Given this list of marker genes Slc6a1, Slc38a1, Eppin, Itga8, Rtn2, Pdpn, Treml4, Clec4e, Trpv1, Skint2, Adam6b, Tpo, Tnfrsf4, H2-M11, Hmgb1, Atp5f1a, Cd209d, Adgrf5, Abcg2, Hrg (NCBI Gene Id 94175), Btn2a2, Ager, Skint5 (NCBI Gene Id 670512), Chrnb2, Cd200r2, Cxcr2, Stx4a, Ly6a, Ror1, Fcgr2b, Pam, Picalm, Ctnnd1 (catenin delta 1), Plxnb3, Srpx2, P2rx7 (NCBI Gene Id 18439), Defb22, Robo4, Anxa1, Pdgfb, Fgfbp1, Ceacam13, Mxra8, Vcan, Ncr1, Ccr8, Axl, Ccr1l1, Cd200r3, Lrp4, Prnp, Epo, Antxr2, Pcsk6, Klri1, Hyal5, Sulf2, Fcer1g, Abcc4, Ighg1, Casr (NCBI Gene Id 12374), Klra6, Hhip, Sdc1, Ide, Nectin2, Lag3, Lrfn4, Slc1a2, Epha2, Tlr4, Lrrc8a, Mr1, Rspo2, Aqp11, Clec12a, Clec1b, Areg, Atp5if1, Ror2, Kcnc1, Ntrk1, Scarb1, H2-M10.2, Slc4a1, Hsp90ab1, Tnfrsf14, Nrros, Tfrc, Btnl10, Vtcn1, Anxa2, Il15, Slc4a4, Fzd3, Eno2, Ighd, Skint1, Kcnq2, Slc26a9, Gp5, Hspa2, Mas1, P2rx2, Ece1, Kcna4, Fap, Phb1, Psg28, Cd2, Clec4a3, Ptprc, Crlf2, Clec9a, Fgf22, Kcnk2, H2-Q10 (NCBI Gene Id 15007), Adgre4, Ccrl2, Crlf1, Lrp8, Treml1, Adora2b, Fga, Adam10, Btla, Cd80 (NCBI Gene Id 12519), Neu1, Hyal4, Il1rap, Cdh5, Adgrg6, Timp2, Atp6ap2, Havcr1, Kcnj3, Grin2b (NCBI Gene Id 14812), Vamp4, H2-M10.5, Dcstamp, Kcnh2, Il31ra, Lrp2, Sell, Slamf6, Slc24a1, Tyrobp, B2m, P2rx1, Btnl6, Igsf5, Nrp1, Pdcd1, Enpep, Eno1, Il4, Msn, Ramp2, Ptn, Vegfa, Cd19, Slitrk3, Pxdn, Prn, Irak1, Asgr2, Notch1, Adam30 (NCBI Gene Id 71078), Cd86, Ackr3, Akp3, Lifr, Ctss, Enox1, Itgax, Cdh2, Gjd3, Pcsk9, Mill1, Ctsz, Itga6, Vasn, Plet1, Folr1, Fcgr4, Capn5, Cd36 (NCBI Gene Id 12491), Layn, Il7r, Cacng4, Clec5a, Ackr2 (atypical chemokine receptor 2), H2-M1, Notch4, Trgc1, Trgv1, Cdh17, Apoh, F3, Jam3, Ldlr, Nfam1, Prss8, Ceacam2, Scube3, Kcnj6, Fcer2a, Pkd1l3, Trhr, Cd53, Lepr, 6030468B19Rik, Fcrl5, Aqp4, Gsr, Pdgfra, Ccr7, Skint11, Gp1ba (NCBI Gene Id 14723), Cuzd1, Clcn3, Sdc2, Ace2, Ermap, Il27, Wnt3a, Pla2r1, Thbs1, Islr2 (immunoglobulin superfamily containing leucine-rich repeat 2), Notch3, Kcnh1, Nlgn1, Adra2b, Atp5po, Usp14, Mbp, Spam1, Icos, Lgals3, 2410137M14Rik, Spn, Mfge8, Psg26, H2-M3, Ngfr, Tspan32, Oscar, H2-Q6, Cd22, Wnt7b, Cntn2, Gria2, Itga11, Flot1, Itgal, Atp1a2, Bmp2, Gldn, Fgfr2, Il1r1, Kcnn2, Bcam, Lrp1, Pla2g1b, Icam1, Itga9, Csf2rb2, Sema6c, Tjp2, Cd33, Tns1, Rgma, Cav2, Adam1b, Folh1, Ocln, Erp44, Klra10, Psen1, Gpihbp1, H2-Eb1, Acvr1b, Gpc5, Cd27, Kcne2, Slc9a1, Egfr, Fcrl6, Vamp3, Pdia4, Art2b, Mslnl, Strc, Cntnap2, Lamp3, Klrk1, Egfl8, Chrna4, Clstn2, H2-Q2, Tigit, Il1r2, Il5ra, Cd276, Thbd, Vwf, Fas, Il11ra2, Ceacam12, H2-Ea, Bcan, Aoc3, Abcc2 (ATP-binding cassette, sub-family member 2), Cr2, Neu3, Trpv4, Spag11a, Abcg1, Tln1, Itgad, Arpc2, Il4ra, Pdia3 (NCBI Gene Id 18794), Eno1b, Sorl1, Cp, Tgfb1, Cdon, H2-M10.3, Btnl1, Bmp10 (bone morphogenetic protein 10), P4hb, Musk, Pirb, Iqgap2, Fgf8, Cxcr4, Iglc1, Lrfn5, Fcgrt, F2, Adgra3, Itgb2, Fcrlb, Rtn4rl1 (reticulon 4 receptor-like 1), Ntsr1, Timd6, Htr2c, Amot, Ramp1, Irak4, Rps6kb1, Rorc, Cd209c, Csf1r, Hspa5, Kcnh5, Intu, Slc4a3, Klrd1, Tmprss11d, Shh, Atp1b2, Fut4, Abcb11, Gp2, Sfrp1, Ceacam20, Tspan33, Cdh13, Grin1, Insr, Epha4, Dpp6, Il1rapl2, Cacna1d, Dmd, Trgv5, Cd74, Adam17, Art1, Furin, Hfe, Trpc4, Ptger3, Hcst, H2bc1, Adam7 (NCBI Gene Id 77685), Ceacam3, Adam3, Tspan14, Csf2rb, Tmem8b, Rtn4rl2, Apoa1, Tgfa, Il1rapl1, Tas2r118, Il2ra, Cd200, Ly6d, Cd200l2, S100a10, Il1a, Mill2, Tacr1, Mog (myelin oligodendrocyte glycoprotein), Cd200r1, Zpld1, Il6ra, Cacng2, Igsf21, Bsph2, Ceacam11, Ncam1 (neural cell adhesion molecule 1), Itgb2l, Got2, Gfra3, Kcnb1, Slamf7, Btnl4, Cxcl10, Trem3, Apoa4, C1qbp, Slamf9, F2r (NCBI Gene Id 218465), Clec4a4, Cntfr, H2-Ab1, Clec4a1, Cxcr6, Alpi, Pdgfc, Upk1a, Timd2, Ly6g5c, Serpina5, Pebp1, Gpc1, Adam5, Fcrl1, Itgbl1, Scara5, Clec4f, Tnfrsf1a (tumor necrosis factor receptor superfamily, member 1a), Mpl, Oit3, Dag1, Slc3a2, Adamts7, Itgav, Mrc2, Trem4, H2-T22, Epor, Cd79a (CD79A antigen (immunoglobulin-associated alpha)), Cd226, Itgb1, Sptb, Acvrl1, C5ar1, Cd44, Abcb1b, Synj2bp, Fcer1a, Klre1, Itgb5 (NCBI Gene Id 16419), Lrrc15, Selp, Fam234a, Raet1e, Clec4n, Mgl2, Il9r, Clec10a, Wnt5a, Tnfrsf22, Adam2, Clec14a, Msln, Asgr1, Cd99l2, Klra2, Kcna5, Pkd1, Kcnc4, Tmc1, Dpp4, Adam19 (ADAM metallopeptidase domain 19), Psg18, Ano1 (anoctamin 1, calcium activated chloride channel), Cd14, Adam28, Aamp, H2-M10.4, Bmpr1a, Ly9, Ctsk (cathepsin K), Il15ra (NCBI Gene Id 98822), Tfpi (tissue factor pathway inhibitor), Heg1, Itgb7, Anpep (alanyl aminopeptidase, membrane), Fgb, Lrp6, Il2rb, Sema7a, Amelx, Hyal2, Tmigd1, Pmp22, Gabrg2, Nlgn4l, Pdgfrb, Asic1, Phb2, Arsb, Ckap4, Gpc4, Ccn5, Trpm8, Tfr2, Klra5, Enox2, Cd34, Trf, Tyro3, Psg16, Il11ra1, Fzd4, Psg19, Adam29, Vamp1, Ntm, Trem5, Tnn, Itgae, Rtbdn, P2ry12, H2-T15, Ghrhr, Glra1, Tspan8, Kcna1, Myd88, Myh9, Efna5, Adam32, Ccr3, Trem1, Spa17, Ly6g, Cd63, C3, Drd1, Ltf, Smim1, Ccr2 (C-C motif chemokine receptor 2), Fshr, Adipoq, Pkd2l1, Grm7, Ank3, Itga4, Bace1, Scn5a, Plat, Eng, Clec7a, Gm4787, Adgrv1, Klra7, Raet1d, Cd1d2, Cd38, Scube2, Alcam, Cd274, Muc16, Itga2, Lct, Itgb4, Wnt6, Osmr, Havcr2, Tgfbr3, Psg20, Cd3d, Anxa5, Bmpr2, Itga10, Cxcr1 (C-X-C motif chemokine receptor 1), Ccr5, Clec2f, Slc1a1, Sdc4, App, Lman2, Hmmr, Hsp90aa1, Cfh, Cd5l, Vpreb1a, Cd24a, Slc32a1, Ccr9, Klra8, Sarm1, Ifitm3, Zpld2, Lpar1, Cd200r4, Ntrk2 (NCBI Gene Id 77471), Cx3cl1, Meltf, Adam20 (NCBI Gene Id 384806), Cxcl12, Capn2 (NCBI Gene Id 98318), Gpr37, Ceacam1, Cd59a, Ephb6, Lgals1, Ptprt, Clec2e, Corin, Clec4a2 (C-type lectin domain family 4, member a2), H2-Eb2 (histocompatibility 2, class II antigen E beta2), Boc (NCBI Gene Id 212529), Calr, Klra3, Psg22, Cd83, Pvr, Ackr4, Kcnma1, Clec2g, Tnfsf4, Cd209g, Psg17, Gp6 (glycoprotein 6 platelet), Ly6g6c, Atp1a3, Psg27, Muc17, Wnt1, Ms4a2, Lrpap1, Slc11a2, Slc1a3, Fzd6, Apoe, Erp29, Ccr1, Tnfrsf9 (tumor necrosis factor receptor superfamily, member 9), Skint7 (selection and upkeep of intraepithelial T cells 7), Cfc1, Sfrp4, Tmprss11f, Anxa9, Tlr3, Klra1, Vldlr, Dnai2, Dlk1, Btn1a1 (NCBI Gene Id 12231), Cd6, Zzef1, Ccl21b, Klra17 (NCBI Gene Id 170733), Cxcr5, Ccl19, Adamts15, Tnfrsf12a, Pdgfa, Il18rap, Ulbp1, Pdcd1lg2, Klrb1b, Clstn3, Slc46a2, Ly6c1, Atp5pf, Mif, Clstn1, Septin2, Trdc, Scnn1g, Krt4, Adam1a, Entpd2, Bgn, Cxcl9, Lrfn3, Adam26a, Egfl7, Stab2, Entpd1, Mdga1, Il1rl2, Ache, Dcc, Kiss1r, H2-M2, Psg21, Thsd1, Nid2, Tjp1, Adam39, Duox1, Plvap, Htr3b, Dscaml1, Ly6g5b, Abcb1a, Adam34l, Adam25, Clec12b, Mmp25, Rs1, Ace, Cd69, Igf2r, Skint10, Cd48, Il17rb, Entpd6, Cspg5, Kcnj5, Rala, Slc2a4, Skint8, Tnr, Slc7a11, Art2a, Tlr2, Csf3r, Fcmr, B4galt1, Cd151, Dcbld2, Folr2, Tgfb2, Tnfsf13, Unc5c, Pla2g5, Gm30083, Plg, Itgb3, Ghsr, Ramp3, Cd1d1, Tnfrsf13b, Skint9, Pecam1, Tnfrsf18, Dsg2, Trgc2, Cspg4, H2-Q4, Slc6a3, Cav3, Cd84, Slc7a5, Gfral, H2-T10, Fcrla, Tectb, Hspa8, Il13ra2, Slitrk6, Bsph1, Lipc, Timd5, Ntsr2, Rnpep (arginyl aminopeptidase (aminopeptidase B)), H60b, Unc5d, Tspear, Itga2b, Ccr6, Plppr4, Ly75, Fermt2, Slamf1, Umodl1, Umod, Fcgr3, Ceacam23, Fasl, Itgb6, Cacna1c, Scube1, Sparc, Il12rb1, Hnrnpu, Muc1, H2-DMa, Vsir, Mcam, Slit2, Cd59b, Itgb8, Efnb1, Tgfbr2, Adam9, Clec2i, Krt10, Il13, Cd8a, Klra4, Clic4, Sirpa, Itga3, Adam8, Sigirr, H2-T23, Il13ra1, Mrc1, Serpinf2, Tnfrsf23, Tnfrsf10b, Cd209f, Aimp1, Krt18, Fgg, Lamp1, Tex101 (testis expressed gene 101), Duox2, Cdh1, Epha5, Tek, Azgp1, H2-M10.1, Otoa, Rtp2, Rtn4r, Ighm, Xcr1, Fcrl2, Ctsl, Gabrb3, Slc6a2, Ros1, Nrxn1, Ptprk, Sucnr1, Ndp, Vamp8, Nlgn2, Lrfn1, Neo1, Glrb, H2-T24, Cd28, Cd3g, Adgre5, Adam15, Apmap, Ccr4, Icosl, H60c, Adam21, Klrb1, Cd46, Hpn, Lrrc24, Grem1, Dppa1, Abca1, Skint3, Tnfsf18, Gucy2g, Chrd, Ly6k, Il12a, Stx2, Ambp, Cd8b1, Gypa, Prom2, Gpc6, Scart2, Gprc5b, Adcyap1r1, Hilpda, Lilrb4b, Wif1, Rer1, Cd200l1, Prom1, Klrc3, Klrb1a, Fzd10, Antxr1, Tmem102, S1pr1, H2-D1, Cd209a, Lnpep, Wnt7a, Cd47, Cd4, H1f1, Dip2a, Cd3e, Izumo1r, Il23r, Tmem123, Lmo7, Il18r1, Clec4d, Fam89b, Treml2, H2-M10.6, Itga5, Trem6l, Tspan15, Slc34a1, Il1rl1, Thy1, Cd9, Trpv2, Fgf10, Hspd1, Itga7, Il6st, Cyp2w1, Hjv, Ly6g6d, Cd207, Fzd9, Fgfr3, Chrna7, Cd244a, Cst8, Il17a, Cftr, Lipg, Klrc2 (NCBI Gene Id 16642), Hcn1, Vamp5, Emp2 (NCBI Gene Id 223964), Trgc4 (T cell receptor gamma, constant 4), Sdc3, Tnf, Ephb2, Antxrl, Ceacam5, Cxcr3 (NCBI Gene Id 12766), Jam2, Cd209b, H2-Q7, Elane, Agap2, Trgv3, Lilra5, Car4, Lrrc32, Kcne1, Cd93, Sele, Cx3cr1, Scnn1b, Tirap, Mcemp1, Gfra2, Nradd, Cd55 (CD55 molecule, decay accelerating factor for complement), Ppfia2 (NCBI Gene Id 327814), Fcgr1, Gria1, Tcn2, Btnl9, Map3k5, Ly6g6e, Tgfb3 (NCBI Gene Id 21809), Klri2, Nlgn3, Kcnq3, Adam26b, Scnn1a, Chrna1, Angptl3, Blvra, Ptprj, Ccr10, Vcam1, Gpc2, Enpp3, Grin2a, Hbegf, Skint4, Btnl12, Tnfrsf13c, Tlr8, H2-Q1, Ly6c2, Cav1, Lilrb4a, Il12rb2, Cd248, Plau, Ghr, Cd79b, Rc3h2, Cd163, Adgre1, Il21r, H2-K1, Sema6d, Ceacam10, Agrn, Adam24, Klrh1, Clu, Ajap1, Ciita, Klrb1c, Siglece, Psg23, Trem2, Arsa, Plaur, Ncl, Abca7, Prlr, Cd40lg, Cd5, Lyzl6, Psg25, Klrc1, St14, Col23a1, Ctsb, H2-T3, Ceacam15, Kit, H2-Aa, Ms4a1, Skint6, H13, Adamts9, Clec4b2, Anxa4, Acvr2a, Bst2, Gfra4, Siglech, H2-T13, Epcam, Adtrp, L1cam, Klra9, Clec2d, Robo2, Flt3l, Adam34, Fzd1, Clec4g, Ifng, Cryab, Il12b, Tjp3, Sort1, H2-T5, Ceacam14, Tgfbr1, Tnfrsf11a, Wnt5b, Cd55b, Astn1, Rtp1, Flt3, Trgv2, Notch2, Adam6a, Tmx3, Clec2h, Il17rc, Lbp, Lrfn2, Mmp7, Ada, Lpl, Prnd, Cr1l, Cd209e, Atp5f1b, Psg29, Sulf1, Kdr, Gpc3, Clptm1, Nod2, Itga1, Slc12a1, Bsn, Adgra2, Il2rg, Fzd5, Cripto, Lpar2, Nptn, Gfra1, Acvr1c, Cd40, Itgam, Nt5e, Robo1, Btnl2, Klrb1f, Hnrnpm, Ctla4, H2-M9, Clec4b1, Adam4, Enpp1, H2-M5, Wnt4, Il6, Wfdc6a, here is a description of the gene set: Mouse Gene Set: GOCC_CELL_SURFACE studied in species Mus musculus The external part of the cell wall and/or plasma membrane.